The following is a description of a gene set: Genes predicted to be targets of miRBase v22 microRNA hsa-miR-6080 in miRDB v6.0 with MirTarget v4 prediction scores > 80 (high confidence targets). Human Gene Set: MIR6080 studied in species Homo sapiens from publication Chen Y, Wang X (PMID 31504780), and this is the list of marker genes: MAT2B, DSG1, FAM200C, SLCO3A1, GABRB2 (NCBI Gene Id 2561), TRAM1L1, ADCYAP1, PRR3, PEX5L, SPRED1, PDIK1L, KLF7, CPEB2, KLK8, ZBTB4, ZBTB20, FMC1, STK33 (serine/threonine kinase 33), MNS1, RO60, DARS1, EPC2, ARMH4, PYGO1, CDKL2, CLN6, GPC6, RARB (NCBI Gene Id 5915), PAX6, METTL9, SKIDA1, KCNRG, PDE7B (NCBI Gene Id 27115), ZSWIM2, CSMD1, JARID2 (jumonji and AT-rich interaction domain containing 2), USP13, CACNA1D, SCN2A, ACVR1, MSANTD4, SLC25A46, SPAG8, PLAGL2, NALF2, INAFM2, MYB, RALA